The following is a description of a gene set: studied in species Homo sapiens Human Gene Set: GOBP_SRP_DEPENDENT_COTRANSLATIONAL_PROTEIN_TARGETING_TO_MEMBRANE The targeting of proteins to a membrane that occurs during translation and is dependent upon two key components, the signal-recognition particle (SRP) and the SRP receptor. SRP is a cytosolic particle that transiently binds to the endoplasmic reticulum (ER) signal sequence in a nascent protein, to the large ribosomal unit, and to the SRP receptor in the ER membrane., and this is the list of marker genes: ZFAND2B, SRP72, SRP14 (signal recognition particle 14), SEC61A1, RN7SL3, TTC9-DT, RN7SL2, SEC61A2, SRP54, SRP19, SRPRB, TRAM1L1, SEC63, SRP9, SSR3, SNAP25-AS1, RN7SL1, SEC61B, SRPRA, GJD2-DT, ENSG00000283175, BHLHE40-AS1, TRAM1, SRP68, TRAM2 (translocation associated membrane protein 2)